The following is a description of a gene set: Human Gene Set: GOMF_G_PROTEIN_ALPHA_SUBUNIT_BINDING Binding to a G-protein alpha subunit. The alpha subunit binds a guanine nucleotide. species: Homo sapiens, and this is the list of marker genes: GPSM2, RGS14, F2RL1, RGS10, CCDC88C, PLCD4, HTR2B, GAS2L2, DRD2, GPSM1, GRIA1, RGS4, DRD1, RIC8A, PPP5C, CCDC88A, ADGRV1, NUCB2, SASH1, RGS22, IGF2R, NUCB1, RGS7, RGS1, RIC8B, OPRM1, LPAR3, RGS2, LPAR1 (lysophosphatidic acid receptor 1), F2R